Given this list of marker genes PLA2G4E, PLA2G1B, PLA2R1, PLA2G4C, PLA2G5, PLA2G2A, PLBD1, PLA2G2F (NCBI Gene Id 64600), PLA2G10, PLA2G12A, PLA2G4D, PLA2G4F, PLA2G2D, PLAAT3, PLA2G4A, MBOAT7, PLA2G2E, here is a description of the gene set: In the acyl chain remodelling pathway (Lands cycle), phosphatidylinositol (PI) is hydrolyzed by phospholipases and subsequently reacylated by acyltransferases. These cycles modify the fatty acid composition of glycerophospholipids to generate diverse molecules asymmetrically distributed in the cell membrane. studied in species Homo sapiens part of: Glycerophospholipid biosynthesis Reactome Pathway: Acyl chain remodelling of PI